Given this list of marker genes Cd59b, Cr1l, Hsp90ab1, Il4, Cd59a, Cfh, Cd55, C3, Rab27a, Il13, Cd5l, here is a description of the gene set: studied in species Mus musculus Mouse Gene Set: GOBP_COMPLEMENT_DEPENDENT_CYTOTOXICITY Cell killing caused by the membrane attack complex formed following complement activation.